The following is a description of a gene set: Neighborhood of BUB1B Neighborhood of BUB1B BUB1 budding uninhibited by benzimidazoles 1 homolog beta (yeast) in the MORF expression compendium studied in species Homo sapiens Human Gene Set: MORF_BUB1B, and this is the list of marker genes: ARID3A (AT-rich interaction domain 3A), TTK, ANP32E, MRPS18B, GOT2, BUB1B, MTREX, GLMN, DNMT1, ACTL6A, ABCF1, HMMR, MARS1, KIF20B, TRIP13, CEBPZ, NUDC, PLK4 (NCBI Gene Id 27119), MCM6, MCM2, ESD, PRKDC, CDK1, IARS1, TREX2, TYRO3, YARS1, RAD54L, KHSRP, GTF2A2, SHMT2, ZWINT, TOP2A, CDK11A, ABCE1, RFC3, PLAGL2, CDC7, DLEU1, BUB1, NDC80, ESPL1 (extra spindle pole bodies like 1, separase), IMMT, SRPK1, TARS1, RFC4, CENPA, OXCT1, GARS1, CCT5, HDAC2, KIF14, PLK1, NSD2, CCNA2, HCFC1, TBXA2R, TPX2, NAGA, USP14, BAZ1B, IPO5, TFDP1, DDX46, TMC6, CDKN2C